Given this list of marker genes KRT81, MCTS1, PEX16, EXOSC3, ZNF281, SAP30BP, TIGD3, ZFP28, OAZ3, ZNF582, GUCY1B1, ABLIM1, CRHBP, PIAS2, RBPMS2, ENSG00000269210, CANT1, CHCHD2, SPHK2, NFKBIL1, MRPL9, ZNF560, PMAIP1, CDX4, ZBTB14, ITGAV (NCBI Gene Id 7449), LBX2, ZNF766, KCNAB3, REXO2, TNFAIP8L2, NTN5, GSN-AS1, RECQL5, DNM3, PRRT1, SCG5, LHCGR, MT2A, GTF2A1, SLC8A3, TMEM263, CXCL5, NEUROG1, PLPBP, TLR2, BTBD3, PIP4P2, WDR31, CASP2, PPT2, COCH, ZFHX2, ADGRG6, HNF4A, VWF, IFNAR2, POU2AF1, PTGDR2, WBP1L, LARGE2, FAM83B, AEBP1, ARHGAP27, TANC2, PIGZ, PAQR5, ZFP3, FAM131A, YBX3, ZNF667, STOML2, FSTL1, PABPN1, KDM5B, ATP6V1G2, RSKR, VAMP5, EXOSC2, GPRASP3, ZNF395, HMCES, CDK8, FARP2, VPREB3, CENPV, POU5F1, LAMP1, CNTROB, DHRS12, CALCOCO1, ARL15, HILPDA, NNAT, IPO8 (importin 8), ELAVL2, TBC1D15, PFN2, CHMP4C, ZNF875, CYP26C1 (NCBI Gene Id 340665), NRP2, TNPO3, CCDC34, LANCL1, STX16, SMIM15, CYP7B1, TRAPPC1, TGFBR1, MAP7D3, MAP7D2, here is a description of the gene set: species: Homo sapiens We hypothesized that DNA methylation distributes into specific patterns in cancer cells, which reflect critical biological differences. We therefore examined the methylation profiles of 344 patients with acute myeloid leukemia (AML). Clustering of these patients by methylation data segregated patients into 16 groups. Five of these groups defined new AML subtypes that shared no other known feature. In addition, DNA methylation profiles segregated patients with CEBPA aberrations from other subtypes of leukemia, defined four epigenetically distinct forms of AML with NPM1 mutations, and showed that established AML1-ETO, CBFb-MYH11, and PML-RARA leukemia entities are associated with specific methylation profiles. We report a 15 gene methylation classifier predictive of overall survival in an independent patient cohort (p < 0.001, adjusted for known covariates). Cluster 4 of aberrantly hypermethylated genes in blasts from AML (acute myeloid leukemia) patients. Human Gene Set: FIGUEROA_AML_METHYLATION_CLUSTER_4_UP from publication Figueroa ME, Lugthart S, Li Y, Erpelinck-Verschueren C, Deng X, Christos PJ, Schifano E, Booth J, van Putten W, Skrabanek L, Campagne F, Mazumdar M, Greally JM, Valk PJ, Löwenberg B, Delwel R, Melnick A (PMID 20060365)